Given this list of marker genes TIRAP, ACOD1, LYN, PJA2, TLR6, TREM2 (NCBI Gene Id 54209), HMGB1, TLR1, CYBA, F2RL1, MFHAS1, TNFAIP3 (NCBI Gene Id 7128), here is a description of the gene set: Human Gene Set: GOBP_REGULATION_OF_TOLL_LIKE_RECEPTOR_2_SIGNALING_PATHWAY Any process that modulates the frequency, rate, or extent of toll-like receptor 2 signaling pathway. species: Homo sapiens